Given this list of marker genes WNT7A, NIPBL, FIG4 (NCBI Gene Id 9896), SETBP1, MGAT2, PTPRF, SMC1A, TAF6, SMC3, EDARADD, KDM6B, USP9X, FAT4, UBR1, KDM6A, EDA (ectodysplasin A), HDAC8, GNE, PEX2, KMT2D, KRT10, IKBKG, SLC25A24, PORCN, PIGL, RAD21, KIF15, CHRNG, BRD4 (bromodomain containing 4), TBX3, CCDC47, ANTXR1, TP63, DLK1, ALG9, TUBB, RTL1, MEGF8, TWIST2, MEG3, here is a description of the gene set: studied in species Homo sapiens Hypoplastic nipples Human Gene Set: HP_HYPOPLASTIC_NIPPLES Underdevelopment of the nipple.